Given this list of marker genes GPR18, SNX4 (NCBI Gene Id 8723), HTR7 (5-hydroxytryptamine receptor 7), H3C6, CADM4, KLHDC10, ARL3, RUNX2, RAD51D, TBXT, PAXIP1, REV3L, WBP4, JRK, BRINP3, ATXN3, NF1, TSPAN2, C1orf216, CAMK4, PART1, KRT2, PAX7, ATRX (ATRX chromatin remodeler), GPR15, RPS6KA5, PHLDB1, IRS2, ZNF500, POLA1, KRT86, TTI1, COX6A2, MAP2, CLPX (caseinolytic mitochondrial matrix peptidase chaperone subunit X), PPP1R1A, ZNF133, POLR2K, GLE1, KIAA0586, GJB5, RFC5, MAD2L1, FIG4, TTLL4, COLGALT2, OR2B6, TFDP2, ZNF134, PVR, NRP2, NPFF, DNAJC16 (NCBI Gene Id 23341), S100A5, GPR19 (G protein-coupled receptor 19), FANCI, ZNF157, PPP5C, SULT2B1, PSG1, MDM2, RECQL, TRIM24, GNG4, CRHR1, GTSE1, CYP2E1, AQP7, PCF11, NR3C2, NXPE3, POU6F2, ATP6V0A2, ZP2, SULT4A1, SLC6A11 (NCBI Gene Id 6538), NRTN, NKRF, BRWD1, ARHGAP11A, TBX19, MSH3, PGM3, TBC1D22A, PRIM2, CPB2, ELAVL2, SPAST, NOS2, CTRL, NCKIPSD, SURF2, ERCC4, RAP1A, SLC4A8, CYP11A1, PDE4D, CAMK2G, EP400, IVL, PHF10, CSTF3 (cleavage stimulation factor subunit 3), CHD9, AMMECR1, LY9, GRIK5, ADCY3, CELA2B, CCNF, DRC3, IL11RA, SLC2A1, LEPROTL1, NMT1, BMP10, ABCB10, FGF18, LPGAT1, GSS, KAZN, PRKACA, ZSCAN26, CPSF4, JADE3, BNIP1 (NCBI Gene Id 662), STARD5, UBE4B, TMEM11 (NCBI Gene Id 8834), EXTL3, HIC2, POP4 (NCBI Gene Id 10775), PPP1R3D, SPRED2, IL13, DTNA, MLLT10, RXRG, ADAM20, PIGF, NFAT5, AMFR, COQ7, SYNJ2, DNA2, RUNX1, FPR2 (formyl peptide receptor 2), AOC4P, PRELID3A, NTNG2, DIMT1, HABP4, MGA, POFUT2, FNTB, NMT2, ZNF202, CDK8, CPEB3, KRR1, COL19A1, PIK3C2A, KLHL18, MSL3 (MSL complex subunit 3), PAX9, STAG1, SMYD5, SYT5, LORICRIN, POU6F1, RREB1, SLC33A1, ESR1, TMEM184B, HOXA11, MKI67, INSIG2 (insulin induced gene 2), ABO, CDC73, ERC1, CEP162, EPHB2, PIAS2, ZBTB14, PIK3CB, MC5R, ITIH3, NR2C1, RB1CC1, CETN3, IPO9, GPATCH8, TANC2, PSMF1, DKK4, SLC22A6, LTBP4, NR1I2, TSSK2, CDYL, PPP2R5B, BARX2, KLRC4, ATP8B1, BRCA1, CNKSR1, HNF1A, KRT33A, HSPA13, BCL2L11, PPP1R12B, SCAMP1, ZBTB33, IKBKE, GRIP2, GNPAT, SLC16A5, ZBTB40, TAF2, SIGMAR1, GABRB2 (NCBI Gene Id 2561), YAF2, IL16, PLEKHB1, SERPINA4, ATF2, ZNF266, FOXD1, SMG1, NFX1, RRP9 (ribosomal RNA processing 9, U3 small nucleolar RNA binding protein), HOXD4, P2RY10, TPP2, SLC4A3, POLR3F, ARFGEF2, DPT, TAF5, USP20, MAGEA9, ZNF33B, TTLL5, TAF5L, RBMXL1, NEK2, INPP5E, FRYL, IGKV7-3, FOSL1, STAC, EN2, SUPT3H, CFH, ZBTB22, AFF2, ABCB9, ZNF200, UPK1A, SPA17, ABCC8, PDE6A, MFN1, PDK3, here is a description of the gene set: studied in species Homo sapiens Neighborhood of BRCA1 breast cancer 1, early onset in the MORF expression compendium Neighborhood of BRCA1 Human Gene Set: MORF_BRCA1